The following is a description of a gene set: species: Mus musculus Catalysis of the transfer of a substituted phosphate group, other than diphosphate or nucleotidyl residues, from one compound (donor) to a another (acceptor). Mouse Gene Set: GOMF_PHOSPHOTRANSFERASE_ACTIVITY_FOR_OTHER_SUBSTITUTED_PHOSPHATE_GROUPS, and this is the list of marker genes: Fktn, Gnptab, Chpt1, Aasdhppt, Ptdss1, Ptdss2, Pigg, Fkrp, Pgs1, Crls1, Sgms1, Pigf, Pigo, Cdipt, Gnptg, Dpagt1, Cept1, Selenoi, Sgms2, Pign, Samd8